Given this list of marker genes GINS2, ELAVL2, NFIX, CAMLG, RAB7A, TNFRSF11A, HOXC5, CPNE5, CBX6, QNG1, ATXN1, GIGYF2, ATP2B2 (ATPase plasma membrane Ca2+ transporting 2), LDB1, FLRT1, ANGEL1, EFNA3 (ephrin A3), DELE1, FXR2, HLA-DMA, GRK3, POM121, ATXN7L3, ZBTB7A, ARK2C, C9orf153, SHOC2, MED17 (mediator complex subunit 17), BMF, A1CF, BCL2L1, CALM1, TMEM217, IQSEC2 (IQ motif and Sec7 domain ArfGEF 2), ABHD18 (abhydrolase domain containing 18), MUC3A, HNRNPU, FBRSL1, ZBTB7B, U2SURP, TRDMT1, CCDC43, DGKG, DNM3, AP1G1 (NCBI Gene Id 164), DDX17, CNN1, HEPN1, PIAS3, IMPA2, UCK2, RASA4, MINK1, HSF2BP, STEAP2, GAL3ST4, FN3K, RAB5B, ZCCHC13, MLLT11, TEAD2 (TEA domain transcription factor 2), CADM4, PTGIS, KIFBP, TRAK1, ZFP36L1, AMT, ZNF529, CNTFR, MAP4K4, NUFIP2, TUBB4A, TRIM71, TBR1, BRPF3, ST3GAL1, BCL7A, VAMP2, NDFIP2, PLEKHB1, QSOX1, ACIN1, ZNF385A (zinc finger protein 385A), MECP2, ATG2B, IGF2BP1, COPG2, ARSB, SLC39A2, PHOSPHO1, MND1, P3R3URF-PIK3R3, POLR2M, CASP3, NFIC, SERTAD2 (NCBI Gene Id 9792), ITGA5, GCOM1, GET3, CMIP, SOX12 (NCBI Gene Id 6666), EIF4B, HNRNPK, EFHD2, HOXD13, MSI2, PRKACA, IL2RB, SLC8A2 (solute carrier family 8 member A2), URM1, HDAC9, GAS1, PRRC2C, ZBTB7C, MRPS10, PIK3R3, CX3CR1, DISC1, RBPMS, PGPEP1, MDK, CTNNA2, GNAI3, P2RY8, NAA11 (N-alpha-acetyltransferase 11, NatA catalytic subunit), FARP1, FBXL16, PGM1, UBE2K, SLC39A5, TMEM218, MKX, MYOG, B3GAT1, KCNC3, GDI1, here is a description of the gene set: Genes predicted to be targets of miRBase v22 microRNA hsa-miR-6795-5p in miRDB v6.0 with MirTarget v4 prediction scores > 80 (high confidence targets). species: Homo sapiens Human Gene Set: MIR6795_5P from publication Chen Y, Wang X (PMID 31504780)